Given this list of marker genes ANGPTL6, THSD1, ENPP1, DNMT3A, COL3A1, ENG, MICU1, ZNFX1, TGFBR3, ALX4, ABCC6, MSX2 (NCBI Gene Id 8053), here is a description of the gene set: Human Gene Set: HP_ENCEPHALOMALACIA Encephalomalacia Encephalomalacia is the softening or loss of brain tissue after cerebral infarction, cerebral ischemia, infection, craniocerebral trauma, or other injury. studied in species Homo sapiens